Given this list of marker genes IFT70B, ATIC, PMEPA1, SUGT1, SPPL2B, LRPAP1, HINT3, LDHA (NCBI Gene Id 3939), COL3A1, CHEK1, S100A4, DGCR6, TTC39B, SEMA6C, FABP1, here is a description of the gene set: species: Mus musculus Human Gene Set: TERAMOTO_OPN_TARGETS_CLUSTER_4 from publication Teramoto H, Castellone MD, Malek RL, Letwin N, Frank B, Gutkind JS, Lee NH (PMID 15516973) Activated forms of Ras family members are prevalent in many cancers where Ras mutants transduce signals essential for transformation, angiogenesis, invasion and metastasis. As a cancer progression model, we used NIH3T3 cells to explore the mechanism of Ras-induced tumorigenesis. Ras family mutants H-RasV12 and Rit79L strongly induced foci formation, while Rho family mutants RhoA-QL, Rac1-QL and Cdc42-QL were less effective. A comparison of downstream transcriptional targets of Ras and Rho family members using a 26 383 element cDNA microarray revealed that the osteopontin (OPN) gene exhibited the best correlation between magnitude of gene expression change and level of foci formation (r=0.96, P<0.001). In association with H-RasV12- and Rit79L-mediated transformation, foci secreted OPN protein and upregulated the OPN receptor CD44, suggesting the novel initiation of an aberrant OPN-CD44-Rac autocrine pathway. In support of this were the following observations. First, RGD-deficient OPN protein-binding activity was present in H-RasV12-transformed cells but not in control cells, and binding activity was inhibited by the CD44 blocking antibody. Second, foci formation, cell invasion and Rac activity were induced by H-RasV12 and inhibited by the CD44 blocking antibody. Third, foci formation by H-RasV12 was substantially reduced by a short interfering RNA (siRNA) specifically targeting OPN expression for knockdown. Fourth, H-RasV12-mediated transformation was not blocked by the GRGDS peptide, suggesting that OPN effects were not mediated by the integrins. Lastly, OPN knockdown affected the downstream expression of 160 '2nd tier' genes, and at least a subset of these genes appears to be involved in transformation. Indeed, four genes were selected for knockdown, each resulting in a disruption of foci formation and/or invasion. These results underscore the role of aberrant autocrine signaling and transcriptional networking during tumorigenesis. Cluster 4: genes whose up-regulation peaked 4 days after knockdown of OPN by RNAi in the NIH3T3 cells (fibroblasts) transformed by activated HRAS.